The following is a description of a gene set: Any process that modulates the frequency, rate or extent of epithelial cell proliferation involved in lung morphogenesis. Human Gene Set: GOBP_REGULATION_OF_EPITHELIAL_CELL_PROLIFERATION_INVOLVED_IN_LUNG_MORPHOGENESIS studied in species Homo sapiens, and this is the list of marker genes: CDC42, HMGA2, FGFR2, FOXP2, WNT2 (Wnt family member 2), NFIB, SOX9, FGF7, SRSF6